Given this list of marker genes P4HA1, P4HA3, P4HTM, P4HA2, EGLN1, EGLN2, EGLN3, P4HB, here is a description of the gene set: Catalysis of the reaction: peptidyl L-proline + 2-oxoglutarate + O2 = peptidyl trans-4-hydroxy-L-proline + succinate + CO2. Human Gene Set: GOMF_PEPTIDYL_PROLINE_4_DIOXYGENASE_ACTIVITY species: Homo sapiens